Given this list of marker genes USF1, OGT, KAT2B, MLXIPL, USF2, NCOA1, SRF, here is a description of the gene set: Human Gene Set: GOBP_CARBON_CATABOLITE_REGULATION_OF_TRANSCRIPTION A transcription regulation process in which the presence of one carbon source leads to the modulation of the frequency, rate, or extent of transcription of specific genes involved in the metabolism of other carbon sources. species: Homo sapiens